Given this list of marker genes Unc5a, Tubb3, Dscam, Unc5d, Shtn1, Unc5b, Unc5cl, Unc5c, here is a description of the gene set: The series of molecular signals initiated by the binding of a netrin protein to its receptor on the surface of the target cell, and ending with the regulation of a downstream cellular process, e.g. transcription. Netrins can act as chemoattractant signals for some cells and chemorepellent signals for others. Netrins also have roles outside of cell and axon guidance. Mouse Gene Set: GOBP_NETRIN_ACTIVATED_SIGNALING_PATHWAY studied in species Mus musculus